The following is a description of a gene set: species: Mus musculus Binds to and stops, prevents or reduces the activity of telomerase. Mouse Gene Set: GOMF_TELOMERASE_INHIBITOR_ACTIVITY, and this is the list of marker genes: Ten1, Pinx1, Acd, Mcrs1 (NCBI Gene Id 97957), Pif1, Pot1a, Pot1b